The following is a description of a gene set: Mouse Gene Set: REACTOME_CHYLOMICRON_REMODELING Chylomicron remodeling studied in species Mus musculus, and this is the list of marker genes: Apoa4, Apoc2, Apoa5, Apoa2, Apoc2l, Apob, Apoa1, Apoe, Gpihbp1, Lpl